The following is a description of a gene set: studied in species Homo sapiens Diseases of signal transduction by growth factor receptors and second messengers Human Gene Set: REACTOME_DISEASES_OF_SIGNAL_TRANSDUCTION_BY_GROWTH_FACTOR_RECEPTORS_AND_SECOND_MESSENGERS, and this is the list of marker genes: FGF5, CD80, EML4, PIK3R5, SYVN1, ACTG1, FZD8, PPP1CB, ATG7, JAG1, JAK2, TBL1XR1, PLCG1, STAT3, LMO7, AGO3, NTRK3, ALK, CLIP1, MYC, RHOG, PSEN1, POLR2A (RNA polymerase II subunit A), MAPK1, GAB1, PRF1, KIF5B, IRF4 (NCBI Gene Id 4592), BAD (NCBI Gene Id 572), GAB2, UBC, WDR48, ZAP70, UBB, AXIN1 (axin 1), PHB1, ERBB2, HHAT, RAC2, YWHAB, PDGFB, PDGFA, CD28, FGF16 (fibroblast growth factor 16), SQSTM1, HBEGF, KIT, NEURL1, HDAC3, JAG2, MRAS (NCBI Gene Id 654181), ZC3HC1 (NCBI Gene Id 51530), FGFR2, FGF2, DKK4, BCL2L11, PIK3R6, ADAM17, HRAS, PDGFRB, ZC3HAV1, PSMC2, HDAC7, DLL4, TPM4, CEP43, AKT1, PRKAR1A, ESR1, SMAD4, CLCN6, FGFR3, ARRB2, MAPKAP1, PPP2R5B, TNKS2, PDPK1, TP53, EPGN, IQGAP1, PTPN6, PSMC4, CARS1, HDAC9, FGF9, NCOR2, MOV10, PPM1B, PSMC5, ATIC, PSMD3, PPP2R1A, PORCN, CAMK2A, POLR2H, IL10, CREBBP, ZMYM2 (NCBI Gene Id 7750), TPR, PSMA1, CDKN1A, FZD5, FGF1, LMNA, TSC2, PSMA7, PRR5, CTNNB1, DUSP6, STAT1 (NCBI Gene Id 6772), HDAC4, CNKSR2, CASP9, CSNK1A1, PPP2CB, AGTRAP, FZD6, HDAC5, VCP, CD19, KREMEN1, MIB2, CNKSR1, FGF20, FGFR1, RBPJ, JUN, PSMD2, CUL1, MARK3, MAML1, ADRM1, IL22, TCF7L2, PSMC6, BCR, RICTOR, TRAT1 (NCBI Gene Id 51488), PIK3R3, KDR, POLR2I, BRAF, NCSTN, NCBP1, DKK1, PPP2R1B, GOLGA4, LYN, HGF, CD86, PIK3CG, SEM1, CALM1, EGFR, PIK3AP1, ITGB3, DHH, KLC1, SND1, DUSP8, TYK2, STAT5B, CNTRL, NRAS, KAT2A, PIK3R1, FGF4, FOXO3, KSR1, MYH9, MAML2, NTF4, PSMD8 (proteasome 26S subunit, non-ATPase 8), MPRIP, PTPN11, DCTN1, ARRB1, HSP90AA1, AP3B1, BRAP, PSMD11, FRS3, DLL1 (NCBI Gene Id 28514), NEURL1B, ERLIN2, SEC31A, DUSP9 (NCBI Gene Id 1852), KITLG, BIRC6, KAT2B, CDK8, WDCP, NOTCH1, FXR1, NRG2, FLT3LG, FGF6, MYO18A, PSMA2, RNF213, MAMLD1, CREB1, SEL1L, PTEN, CPSF6, MAP2K2, PIK3CB, PSMB4, KLB, LCK, FBXW7, TFG, APH1B, AKT1S1, JUNB, CTBP2, HDAC2, RAP1A, AKT2, AMER1, STAT5A, POLR2B, UBA52, ITGA2B, BIN2 (NCBI Gene Id 51722), VCL, ESRP1, ERBB4, SRC, FAM114A2, SPRED3, TGFB1, LRP5, PSMC3, TGFBR1, CHUK, MIB1, SHH, CAMK2B, TRIM24, CEBPB, FN1, FLT3, GSK3B (NCBI Gene Id 2932), WNT3A, FGF23, APH1A, DKK2, PPFIBP1, BCL2L1, DUSP7, GSK3A, ICOS, TGFBR2, HDAC11, IRS1, AGO4 (NCBI Gene Id 54791), LRP6, TNRC6C (NCBI Gene Id 57690), MAPK9, NR4A1, TGFA, DUSP10, FZD4, PPP1CC, MET, FGF22, POLR2L, CLTC, PSMC1, CCNB1, POLR2F, NCOR1, RPS6, BAG4, RB1, POLR2C, APBB1IP, AGGF1, RAP1B, TPM3, HES5, FGFR1OP2, ADAM10, NTRK2, SKP1, SHOC2, GCC2, MAPK3, PIM1, AGO2, ACTB, HDAC1, PSMA4, CTBP1, POLR2D, PPP2R5D, PSMD1, STRN, DNMT1, KSR2, PPP2CA, FOXO4, HEY1, SOS1, PAPSS1, SPRED1, RPS6KB2, HES1, PIK3CA, MTOR, FIP1L1, IHH, RANBP2, KDM7A, FRS2, RAF1, FGFR4, NPM1 (NCBI Gene Id 4869), EEF1G, BDNF, BCL2A1, BTC, VWF, LRRFIP1, MAP3K11, HIP1, OS9, FOXM1 (forkhead box M1), SPRED2, CDKN1B, VAV1, PTPN12, PSMB6, HEYL, POLR2J, ERBIN, KL (NCBI Gene Id 9365), TENT4A, PSMD12, ERLEC1, PPP2R5C (protein phosphatase 2 regulatory subunit B'gamma), HDAC8, AGO1, KIAA1549, PPP2R5A, HDAC10, MIR21, PSEN2, GZMB, CAMK2D, MCL1, NRG4, FGF3, FGF19, GOLGB1, PSMD14, QKI, CDC37, FGF18, TWIST1, PEBP1, POLR2K, SPTBN1 (NCBI Gene Id 91654), CUX1, CAMK2G, RBX1, IL10RA, FGF7, ARAF, FOXO1, PPP2R5E, NF1, PSENEN, EGF, ZFYVE9, PSMB5, MAML3, FGG, RRBP1, KREMEN2, HEY2, AREG, YES1, TRAK1, POLR2E, PSMA6, PSMB1, PSMB3, MAPK8, SMAD2, GTF2F1, FGF17, AKAP9, PSMD6, GRB2, RAC1, FGF10, EP300, FYN, CSK, MECP2, EREG, HDAC6, PSMB7, RNF43, AGK, BCL11A, PSMB2 (NCBI Gene Id 5690), KRAS, ETV6 (ETS variant transcription factor 6), TRIP11 (thyroid hormone receptor interactor 11), NTF3, CBL, AKT3, DUSP16, EIF2AK3, GTF2F2, SMAD3, FOXO6, MLST8, PSMD7, MSN, TNKS, PSMA3, MDM2, MAP2K1, NRG1, TLN1, IRS2, CCNC, FGF8, FKBP1A, APC, NCBP2, PIK3R2, PSMD13, FGA, PSMA5, SHC1, DERL2, FGB, PDGFRA, SNW1 (NCBI Gene Id 22938), NRG3, PIK3CD, RPS27A, NOX4 (NADPH oxidase 4), ESR2, ERBB3, FAM131B, KANK1, TBL1X, POLR2G